Given this list of marker genes SLC28A1, SLC43A3, SLC29A3, SLC28A3, SLC29A1, SLC28A2, AQP9, SLC29A2, here is a description of the gene set: species: Homo sapiens Human Gene Set: GOBP_PURINE_NUCLEOBASE_TRANSMEMBRANE_TRANSPORT The process in which a purine nucleobase is transported across a membrane.